Given this list of marker genes Haus7, Arf6, Traf3, Rac1, Traf5, Traf4, Traf2, Cdc42, Traf1, Adra2a, here is a description of the gene set: Mouse Gene Set: GOMF_THIOESTERASE_BINDING species: Mus musculus Binding to a thioesterase.